The following is a description of a gene set: This event has been computationally inferred from an event that has been demonstrated in another species.<p>The inference is based on the homology mapping from PANTHER. Briefly, reactions for which all involved PhysicalEntities (in input, output and catalyst) have a mapped orthologue/paralogue (for complexes at least 75% of components must have a mapping) are inferred to the other species. electronically inferred by orthology from the curated human pathway species: Mus musculus Reactome Pathway: Biosynthesis of specialized proresolving mediators (SPMs) part of: Metabolism of lipids, and this is the list of marker genes: Cyp3a16, Cyp1a2, Cyp3a25, Ptgs2, Cyp2e1, Cyp3a41b, Cyp3a57, Alox12, Alox5ap, Cyp2d22, Cyp3a11, Cyp2c65, Cyp3a44, Cyp1a1, Gpx4, Lta4h, Cyp2c66, Cyp3a41a, Alox15, Cyp3a13, Ephx2, Ltc4s